The following is a description of a gene set: part of: Reversal of alkylation damage by DNA dioxygenases ALKBH3, like ALKBH2, is a homolog of E.coli alpha-ketoglutarate- and Fe(II)-dependent dioxygenase AlkB that oxidizes methyl groups on alkylated DNA bases and releases them as formaldehyde. Like ALKBH2, ALKBH3 removes 1-methyladenine (1-meA) and 3-methylcytosine (3-meC) from methylated polynucleotides in an alpha-ketoglutarate-dependent reaction and regenerates unsubstituted bases. Like ALKBH2, ALKBH3 can also repair 1-ethyladenine (1-etA) residues in DNA with the release of acetaldehyde. While ALKBH2 has a preference for double strand DNA (dsDNA), ALKBH3 has a preference for single strand DNA (ssDNA). ALKBH3 efficiently repairs dsDNA in the presence of ASCC3 DNA helicase, which unwinds dsDNA, thus providing the single strand substrate for ALKBH3. Reactome Pathway: ALKBH3 mediated reversal of alkylation damage studied in species Homo sapiens, and this is the list of marker genes: ASCC2, ASCC1, ALKBH3, ASCC3